Given this list of marker genes SLIT2, MEIS3P1, SLC25A3, PHLDA3, TFPI, COL6A2, HOMER3, SLC39A7, DKK1, CTSK, DUSP14 (NCBI Gene Id 116242), NME7, LARGE1, NUDT15, SYNDIG1, UTP25, TSR3, RBP1, SLC31A2, POMP, TBK1, MT1E, SEPTIN2, DOK5, ADAM19, CREG1, TMCO3, MLLT11, ZCCHC24, GYG2, MAP2K2, C11orf24, TENM4, BAALC, UCK2, BCL2L2, ARHGEF40 (Rho guanine nucleotide exchange factor 40), AKR1B10, ANXA3, SLC16A1, SRD5A1, CPQ, PSMA3, DNAJC6, FARP1, NAV2, BHLHE40, KIAA1549L, ATF3, ELOVL1, NAA10, LTBP1, FKBP9, FGF2, EIF2S2, IQCK, BACE1, EYA1, ZC2HC1A, OLFML3, NUDC, SAP30, PON2, COPS6, FST, ACTN1, CDH2, TGFBR3, RBCK1, SFRP1, NT5DC2, TNFAIP1, UST, DENND5A (NCBI Gene Id 23258), TMEFF1, ADGRL2, COX17, BNC2, RECK, ADORA2B, BEX1, SRPX2, GSTT2, CD59, RXRA, C6orf120, TFPI2, PDLIM2, TFE3, TFG, RRAS, KLF4, ADAMTS3, DERL1, NTAQ1, EOGT, MMP1, IPO7, SMUG1, TUBB2A, TNFRSF10B, YARS2, INA, ANTKMT (adenine nucleotide translocase lysine methyltransferase), PTOV1, DHRS7, PRRG1, PTGS1, EXT1, BEX3, STRAP, SLC6A1, ME1, GULP1, STK3, ATXN1, SSH1, CALR, NID1, FNBP1L, GLIPR1, TRIM2, CDC42BPA, MYG1, SEC13, TARS1, COPS7A, LCMT1, DLG5, KATNBL1 (NCBI Gene Id 91186), MTMR2, TWIST1, RAD23B, KALRN, FAM200C, EMILIN1, PF4V1, TLE1, COL1A1, SAMD4A, RPS6KA2, DACT1, PLXNA1, TMA16, SIL1, EMC3, ARHGAP29, LIMS1, SLC24A1, STAM2, ARMCX1, TPST1, COPB2, CREB3L1, TNFRSF12A, LRRC15 (NCBI Gene Id 131578), PHLDA1, PCDH7, MCFD2, MEST, SLC25A4 (solute carrier family 25 member 4), OLFML2A, BMERB1, DPY19L1, GCLM, UAP1, PNPLA4, COPZ2, RTL8C, DNM1L, PDLIM5 (PDZ and LIM domain 5), PPP2R3A, TMEM100 (NCBI Gene Id 55273), MFAP5, ASL, RRBP1, PDGFRL, RPL39L, GAS1, LRIG1, ITSN1, CRTAP, BPNT2, GLT8D2, HAS2, IGFBP5, RNF2, RABIF, KCNK1, SLC6A8, CRYBG3, EIF4G1 (eukaryotic translation initiation factor 4 gamma 1), PDHX, LDOC1, POLR2L, SS18, SPA17, SCG5, CHCHD3, here is a description of the gene set: Human Gene Set: GSE1460_CD4_THYMOCYTE_VS_THYMIC_STROMAL_CELL_DN Genes down-regulated in comparison of CD4 thymocytes versus thymic stromal cells. from publication Lee MS, Hanspers K, Barker CS, Korn AP, McCune JM (PMID 15210650) Subpopulations of human fetal thymocyte and circulating naïve T cells were obtained through FACS sorting, including CD3-CD4+CD8- intrathymic T progenitor cells (ITTP), CD3intCD4+CD8+ \double positive\ thymocytes (DP), CD3highCD4+CD8- \single positive\ thymocytes (SP4), CD3+CD4+CD8-CD45RA+CD62L+ naive T cells from cord blood (CB4+), and CD3+CD4+CD8-CD45RA+CD62L+ naive T cells from adult blood (AB4+). studied in species Homo sapiens